Given this list of marker genes TMEM214, OCRL, RBM44, ENTREP3, AHNAK2, TINF2 (TERF1 interacting nuclear factor 2), COPS7B, SMURF1, KLHDC8A, SLC25A20, CDH26, MRPL49, TPPP, S100A3, F12, POLR2F, IQSEC2, CSN2, NDUFAF5, SAR1A, PRKACB, XYLB, GNAO1, ABCG4, SMC1A, RFFL, RET, SYT11, F9, VAX1, AKTIP, SLC9A1 (NCBI Gene Id 6548), MPDU1-AS1, RIMS4, POU2F2, NREP, ADD1 (adducin 1), FAM222B, SKI, SLCO1A2, AUTS2, KDELR2 (KDEL endoplasmic reticulum protein retention receptor 2), RNF157, MEX3A, HOXA2, TRIM67, GSDMA, SLC5A8, CASTOR2, COP1, LZTS3, ZBTB7B, EEPD1, ATF7, AZGP1, PRIMA1, KIRREL3, ZBTB40, SLC30A3, ZNF703, PITPNB, CCDC141, LENG8, MPIG6B, DNAAF9, CRTC1, WIPF1 (WAS/WASL interacting protein family member 1), TRIOBP, CARNS1, SOX12, DOK2, CCDC30, NR3C1, CAPN15, AGAP3, EXPH5, POU2AF1, MRPS14, POU3F4, LRP10, NRN1, NPLOC4, FAM219A, STK24, MRPL43, NDUFA10, SDC3, FHIT, NPTXR, DSCAML1, SALL2, GLUL, GNRHR, PSMB2, CLMP, C20orf96, IRX5, RUSC1, TRIM34, NOVA2, TM4SF20, CLIC5, FAM78B, CDH24, ZMYM3, CPLX3, DUSP8, KSR2, SLC13A5, HAPLN4, PIANP, IRX6, ZNF384, ST7, TMEM184B, CYGB, KRTAP5-7, TRIM6-TRIM34, PRRC2B, KDM2A, CAMKMT, PACS1, LRSAM1, CLPTM1, ERC2, ZNF792, USB1, PDX1, MYBPC1, SARS2, UBR4, RAB37, HLA-DPB1, MOBP, LRP6, ANGPTL2, KLK4, ACVR1B, FOXP4, RPRD2, TOM1L2, ZCCHC14, FAM120C, MANBAL, LMLN, PLXNA4, here is a description of the gene set: from publication Chen Y, Wang X (PMID 31504780) Human Gene Set: MIR4779 Genes predicted to be targets of miRBase v22 microRNA hsa-miR-4779 in miRDB v6.0 with MirTarget v4 prediction scores > 80 (high confidence targets). species: Homo sapiens